Given this list of marker genes STAG2, RPL34, SYNPO, FHL2, PARP8, TLR6, HPCAL1, PTPRCAP, HMCES, USE1, PARP6, TRPV2, S1PR4, ANGPTL2, BABAM1, PLXND1, MAN2B1, MARCKSL1, NFKB1, RELA, HHEX, CTDSP2 (NCBI Gene Id 51589), GAS8, PDRG1, DSG2, ZFP36L2, RNF145, TSPAN32, DUSP6, C12orf57, RGS10, PPP1R18, LCLAT1, SLC29A1, CDHR5, CLCN4, RBM38, CAVIN3, ITIH5 (inter-alpha-trypsin inhibitor heavy chain 5), TIMELESS, CD5, HLA-DMA, MAD2L1BP, CCNDBP1, CD8A, SLC9B2, RNASET2, ITIH1, ICAM2, BTRC, LYRM2, MOV10, SPNS1, H3-4 (H3.4 histone, cluster member), LAPTM5, PSME2, MAP1LC3B, MAST2, PSME1 (NCBI Gene Id 5720), PNPLA2, NAT1, XRN2, HMOX2, RERE, CYTH2, BTK (Bruton tyrosine kinase), ARPC3, OXCT1, PSEN2, SIDT2, POLG, SLFN12L, RPL7, TAP2, GATA3, CSK, ISG20, EPHX1, USP38, LITAF, PTPN1 (protein tyrosine phosphatase non-receptor type 1), CHCHD6, HMGB3, FH, CDKN1B, SARAF, CHCHD10, PLEKHO1, CD79B, CCL25, IRF9, NRP1, TAPBP, ZNF787, KLF2, MFSD1, POLD1, CCND2, ZFPM1, ENO3, PEX5, LRP10, WNT10A, IL16, INCENP, HNRNPM, ACSS1, TMC6, PABPC1, RPS5, ESYT1, PTPRA, TCF7, PIGS, ARPC1A, IFIH1, EXOSC10 (exosome component 10), PPP2R3C, PIGX, ARHGAP1, KCNJ8, GOLPH3L, CD8B, TAP1, MBTD1, FAM3C, C2CD3, IL6R, PTPRS, GLE1, SPATA13, MAP4K1, KRT16, CMTM3, RPS11, XPO6, USP48, SNRK, GPSM3, NRBP1, GNPAT, STARD3, RNF26, RALY, VPS53, ZNF692, SLC4A2, GATA4 (GATA binding protein 4), PRKD2, CTSS, ITM2A, LIG1, PHC2, TIMM10B, LTA4H, CFH, GNB2, PPOX, CD9, FRMD8, ENTPD5, DGKA, SEPTIN6, CASP7, ZNF277, RIMOC1, NFATC1, NSMCE1, IFNAR1, VCAM1, PITPNC1, LGALS9B, NAA38, RIPOR2, CAPG, WDR26, ADGRE5, SIPA1, GLB1, UBR7, ISYNA1 (NCBI Gene Id 51477), HDAC1, OTUD7B, TMEM59, TXNDC12, MYB, ABCB4, IGHM, GABARAP, TMEM126A, BCL2L11, NEK7, NNT, TSC22D4, CMPK2 (NCBI Gene Id 129607), EVI2A, POMP, GOLM1, PROS1, CLN3, here is a description of the gene set: studied in species Homo sapiens Differentiation of naive CD8 T cells into cytotoxic effector cells requires three distinct signals- antigen (signal 1), costimulation -B7-1 (signal 2) and cytokine, either interleukin-12 or interferon-a/b (signal 3). Interaction of naive CD8 T cells with antigen and B7-1 programs cell division and proliferation whereas the presence of cytokines- IL-12 or IFNa/b promote survival, differentiation and memory establishment. In the absence of signal 3, the cells interacting with antigen/B7-1 undergo tolerance induction. The objective of this study was to elucidate the mechanisms how the provision of signal 3 promotes differentiation and averts tolerance induction in CD8 T cells. Trichostatin A is a pharmacological agent that inhibits histone deacetylase activity, hence regulating chromatin structure and gene expression and differentiation in many cell types. Gene signature profiles of IL-12, IFNa/b and trichostatin A stimulated cells were compared to elucidate the molecular mechanisms of gene regulation. Oligonucleotide microarray analysis is carried out to determine the extent and molecular nature of the CD8 T cell differentiation program induced by IL-12 or IFNa/b in concert with antigen and B7-1 signal. from publication Agarwal P, Raghavan A, Nandiwada SL, Curtsinger JM, Bohjanen PR, Mueller DL, Mescher MF (PMID 19592655) Genes up-regulated in comparison of unstimulated CD8 T cells at 48 h versus CD8 T cells at 48 h after stimulation with IL12. Human Gene Set: GSE15930_STIM_VS_STIM_AND_IL12_48H_CD8_T_CELL_UP